The following is a description of a gene set: species: Mus musculus Intestinal polyposis, a precancerous neoplasia, results primarily from an abnormal increase in the number of crypts, which contain intestinal stem cells (ISCs). In mice, widespread deletion of the tumor suppressor Phosphatase and tensin homolog (PTEN) generates hamartomatous intestinal polyps with epithelial and stromal involvement. Using this model, we have established the relationship between stem cells and polyp and tumor formation. PTEN helps govern the proliferation rate and number of ISCs and loss of PTEN results in an excess of ISCs. In PTEN-deficient mice, excess ISCs initiate de novo crypt formation and crypt fission, recapitulating crypt production in fetal and neonatal intestine. The PTEN-Akt pathway probably governs stem cell activation by helping control nuclear localization of the Wnt pathway effector beta-catenin. Akt phosphorylates beta-catenin at Ser552, resulting in a nuclear-localized form in ISCs. Our observations show that intestinal polyposis is initiated by PTEN-deficient ISCs that undergo excessive proliferation driven by Akt activation and nuclear localization of beta-catenin. Genes down-regulated in the intestine after the tissue specific knockout of PTEN by Cre-lox. Human Gene Set: HE_PTEN_TARGETS_DN from publication He XC, Yin T, Grindley JC, Tian Q, Sato T, Tao WA, Dirisina R, Porter-Westpfahl KS, Hembree M, Johnson T, Wiedemann LM, Barrett TA, Hood L, Wu H, Li L (PMID 17237784), and this is the list of marker genes: PTN, JUNB, VEGFA, FOXO3, PSMD2, TGFA, CCNG2